The following is a description of a gene set: part of: Digestion Dietary lipids such as long-chain triacylglycerols and cholesterol esters are digested in the stomach and small intestine to yield long-chain fatty acids, monoacylglycerols, glycerol and cholesterol through the action of a variety of lipases, and are then absorbed into enterocytes. studied in species Homo sapiens Reactome Pathway: Digestion of dietary lipid, and this is the list of marker genes: PNLIP, PNLIPRP1, PNLIPRP2, LIPF, CLPS, CEL, PNLIPRP3